The following is a description of a gene set: Abnormal vitreous humor morphology studied in species Homo sapiens Human Gene Set: HP_ABNORMAL_VITREOUS_HUMOR_MORPHOLOGY Any structural anomaly of the vitreous body., and this is the list of marker genes: TSPAN12, SF3B1, COL9A2, COX7B, KCNJ13, CYSLTR2, GNA11, RB1, PAX6, PRPF8, COL9A3, BCOR, COL11A2 (NCBI Gene Id 494120), BMP4, P3H2, CTNNB1, ARL3, VCAN, TTR, NDP, ZNF408, GNAQ, CAPN5 (calpain 5), NR2E3, BEST1, BAP1, PROC, LRP5, CRPPA, COL11A1 (collagen type XI alpha 1 chain), ZSWIM6, COL9A1, HCCS, NDUFB11, LAMB2, SIX3, RS1, ESAM, PAK2, COL18A1, SMC5, ATOH7, RPGRIP1, HLA-A, ARSK, FZD4, ERBB3, CRB1, COL2A1, PRR12, NF2